The following is a description of a gene set: Mouse Gene Set: REACTOME_RHO_GTPASES_ACTIVATE_NADPH_OXIDASES RHO GTPases Activate NADPH Oxidases studied in species Mus musculus, and this is the list of marker genes: Ncf2, Nox3, Nox1, Pik3r4, Pik3c3, Mapk3, Ncf4, Cybb, Mapk1, Prkcb, Mapk14 (NCBI Gene Id 26416), S100a9, Ncf1, Noxo1, Cyba, Rac2, Mapk11, Noxa1, Pin1, S100a8, Prkcd, Prkcz, Rac1